The following is a description of a gene set: studied in species Mus musculus Any process that activates or increases the frequency, rate or extent of autophagic vacuole assembly. Mouse Gene Set: GOBP_POSITIVE_REGULATION_OF_AUTOPHAGOSOME_ASSEMBLY, and this is the list of marker genes: Pip4k2c, Lrsam1, Snx30, Pip4k2b, Pip4k2a, Rab3gap1, Trim32, Moap1, Snx7, Wdr45, Sh3glb1, Atg2a, Snx4, Ulk1, Ralb, Rab3gap2, Elapor1, Snx18, Wipi1, Becn1